Given this list of marker genes MITF, AIMP1, AKT3, SOX2, MC1R, TFE3, MARK3, YWHAH, LARS1, MC4R, KIT, EEF1E1, MC5R, EDN3, SOX10, AIMP2, TNFSF11, MARS1, WNT3A, MC3R, HDAC1, FOXD3, TFEC, DARS1, POU3F2, ZIC1, CREBBP, EDNRB, SIRT1, ALX3, PAX3, YWHAB, EP300, SOX9, KITLG, YWHAZ, CTNNB1, HINT1, RPS6KA1, CREB1, RARS1, CSF1, MAPK3, EDN1, IARS1, TBX3, KARS1, YWHAG, MAPK1, UBE2I, SUMO1, CDH1, SNAI2, YWHAE, TFEB, POMC, ID1, EPRS1, XPO1, LEF1, QARS1, GSK3B, here is a description of the gene set: Transcriptional and post-translational regulation of MITF-M expression and activity studied in species Homo sapiens Human Gene Set: REACTOME_TRANSCRIPTIONAL_AND_POST_TRANSLATIONAL_REGULATION_OF_MITF_M_EXPRESSION_AND_ACTIVITY